Given this list of marker genes MGAT5B, DAG1, POMGNT1, POMT1, POMT2 (protein O-mannosyltransferase 2), here is a description of the gene set: Core M2 glycans are initiated by beta-1,6-linked GlcNAc extension of core M1 glycans. These structures are primarily found in brain and prostate tissue and account for no more than 5% of brain protein-linked O-glycans. M2 structures play a role in neural cell adhesion and migration (Praissman & Wells 2014; Endo, 2019). part of: DAG1 glycosylations species: Homo sapiens Reactome Pathway: DAG1 core M2 glycosylations